The following is a description of a gene set: Mouse Gene Set: MIR_7011_5P species: Mus musculus from publication Chen Y, Wang X (PMID 31504780) Genes predicted to be targets of miRBase v22 microRNA mmu_miR_7011_5p in miRDB v6.0 with MirTarget v4 prediction scores > 80 (high confidence targets)., and this is the list of marker genes: Camk1d, Aqp3, Sprr2a3, Hoxb9, Sprr2a2, Gfi1, Sprr2a1, Exog, Hipk1, Cand2, Coa4, Tfr2, C1ql2, Alkbh7, Washc4, Mrps18a (NCBI Gene Id 98069), Maob, Krt19, Rraga, Kpna3, Kif9, Agtr1a, Cyp2j6, Zbtb2, Slc25a29, Man1a2, Dnajb2, Madd, Sprr2b, Card10, Rsph4a, Mfap3, Seh1l, Mecp2, Prlr, Astn1, Dpm2, Fbxl20, Ankrd45, Ranbp10